Given this list of marker genes ARSB, TEKT3, FGFR2, ERCC4, PAX9 (paired box 9), ANTXR1, NSD1, NELFA, LRP6, GRHL2, SEC24D, CTSK, POLR3B, SATB1, EFL1, BCOR, TNFSF11, NDUFB11, STAT3, IQSEC2, FOSL2, VDR, NPHS1, PAPPA2, NIPBL, IRF6, SMC1A, LMNA, SETBP1, OBSL1, FGD1, PTCH1, ADAMTS3, HDAC8, LIG4, CHD7, SMARCB1, PDE4D, IDS (iduronate 2-sulfatase), DPF2, RUNX2, ANAPC1, PIGL, OCRL, PIK3R1, WNT10A, EDNRA, ATP6V0A2, LETM1, NAA10, DNAJC21, AMMECR1, SOX11, GNAS, UBR1, ATP6V1B2, ERCC8, CRTAP, DNA2, POLR3A, RIC1, ARID2, SMARCC2, RPS6KA3, PRKAR1A, CBFB, FLII, SMC3 (structural maintenance of chromosomes 3), CYP2R1, GJA1, MMP2, CCBE1, SBDS (SBDS ribosome maturation factor), RECQL, CAMK2B, FAM20A, SLC37A4, SEC23A, PIGA, TGFB1, STX16, PDGFRB, FLNA, CHST3, P4HB, GHR, SOX4, TNFRSF11A, CPLX1, SH3PXD2B, TRIP11, GLI1, CLCN7, TRPS1, TCIRG1, ZEB2, FAT4, EDA2R (NCBI Gene Id 60401), CTBP1, ANKH, EDA, DVL1, ERCC1, ROR2, WNT5A, SLC29A3, SMARCD1 (NCBI Gene Id 6602), FGFR1, PIGG, IKBKG, SMARCE1, AXIN2, SMARCA4, PORCN, RAI1, PTHLH, ARID1A, ENPP1, ZFX, SLC13A5, TWIST2, HDAC4, MIA3, LONP1, DEAF1 (NCBI Gene Id 105376508), KCNJ2, KCNH1, APC2, CYP27B1, TBC1D24, CCDC8, SLC1A2 (NCBI Gene Id 6506), ACP5, EVC2, SNX14, RAD21, BRD4, IL11RA, CUL7, TRIO, SFRP4, SP7, SUOX, SUMO1, LEMD2, TONSL, ADAMTSL1, RECQL4, KCTD1, SNX10, SLC39A13, GNB2 (G protein subunit beta 2), PRKACA, WNT10B, NSD2, ARID1B, CDH11, MYSM1, DYNC2LI1 (dynein cytoplasmic 2 light intermediate chain 1), PIGF, KAT6B, AMER1, ZMPSTE24, GDF5, ABCA5, TAF6, ELMO2, EVC, PRKACB, FGF3, DPYD (dihydropyrimidine dehydrogenase), TGFA, ERCC6, THRA, IGF1, NSUN2, DMP1, SEMA3E, EDARADD, MSX1, here is a description of the gene set: Delayed eruption of teeth species: Homo sapiens Delayed tooth eruption, which can be defined as tooth eruption more than 2 SD beyond the mean eruption age. Human Gene Set: HP_DELAYED_ERUPTION_OF_TEETH